The following is a description of a gene set: studied in species Mus musculus An inflammatory response driven by T cell recognition of processed soluble or cell-associated antigens leading to cytokine release and leukocyte activation. Mouse Gene Set: GOBP_TYPE_IV_HYPERSENSITIVITY, and this is the list of marker genes: Gata3, Fut7, Zp3, Ephb6, Spn, Il20rb